The following is a description of a gene set: species: Homo sapiens from publication Chen Y, Wang X (PMID 31504780) Human Gene Set: MIR6748_3P Genes predicted to be targets of miRBase v22 microRNA hsa-miR-6748-3p in miRDB v6.0 with MirTarget v4 prediction scores > 80 (high confidence targets)., and this is the list of marker genes: POMGNT1, PPP6R3, SCN8A, PTPRB, CCDC191, EGR1, UNC5C, TBC1D16, SEC14L3 (SEC14 like lipid binding 3), MGAT3, TANGO2, ICMT, IQGAP1, CYREN, ABHD15, LOXL3, ABCF2, CTDSPL (CTD small phosphatase like), FUT1, CBX7, SNRPE, SMARCA4, SLC1A3, CAMK1D, HMGN2, GLUL, GLI2, VANGL2, TIRAP, ATP13A4 (NCBI Gene Id 84239), NR2C2, HIF1AN, FAM221B, OAS2 (2'-5'-oligoadenylate synthetase 2), PIWIL3, RDX, IQSEC3, NPTXR, TM9SF4, TNRC6C, CAMKK1, TPPP, BMPR2, SPEG, EIF2A, MAP3K19, ADNP, WDR91, PIK3C2B, ELFN2, PRSS8, SMCO3, ARL10, NMRK1, CCDC88C, SYNPO2, KREMEN2, KCNS1, ACP2 (NCBI Gene Id 96117), ZDHHC3, GPR61, FOXN4 (NCBI Gene Id 121643), HNF1A, TMEM71, UNC5A, SH3PXD2A, LGSN, NAP1L1, TATDN2, METAP2, PODXL, MED31, ANKS1A (NCBI Gene Id 23294), AAK1, TACC2, MEF2D, GDNF, FABP5, LIMS2, EPO (erythropoietin), PDSS2